The following is a description of a gene set: Cluster PAM6: genes changed exclusively in normal liver tissue adjacent to hepatocellular carcinoma (HCC) from mice deficient for TXNIP. species: Mus musculus The molecular pathogenesis and the genetic aberrations that lead to the progression of hepatocellular carcinoma (HCC) are largely unknown. Here, we demonstrate that the thioredoxin interacting protein (Txnip) gene is a candidate tumor suppressor gene in vivo. We previously showed that the recombinant inbred congenic strain HcB-19 has a spontaneous mutation of the Txnip gene, and we now show that the strain has dramatically increased incidence of HCC, and that the HCC cosegregates with the Txnip mutation. Approximately 40% of the Txnip-deficient mice developed hepatic tumors with an increased prevalence in male mice. Visible tumors develop as early as 8 months of age. Histological analysis confirmed the morphology of HCC in the Txnip-deficient mice. Molecular markers of HCC, alpha-fetoprotein and p53, were increased in tumors of Txnip-deficient mice. The upregulation of p53 preceded tumor development; however, bromodeoxyuridine (BrdU) labeling of normal hepatic tissue of Txnip-deficient mice did not reveal increased cell proliferation. Finally, microarray analyses of tumor, non-tumor adjacent, and normal tissue of Txnip-deficient mice highlighted the genetic differences leading to the predisposition and onset of HCC. Our findings suggest that Txnip deficiency is sufficient to initiate HCC and suggest novel mechanisms in hepatocarcinogenesis. Human Gene Set: SHETH_LIVER_CANCER_VS_TXNIP_LOSS_PAM6 from publication Sheth SS, Bodnar JS, Ghazalpour A, Thipphavong CK, Tsutsumi S, Tward AD, Demant P, Kodama T, Aburatani H, Lusis AJ (PMID 16607285), and this is the list of marker genes: PER2, RAB27B, CENPK, PRCP, CREB1, UHRF1, FAM110A, PDLIM5, RNF20, APLNR, CD93, TEF, LEPR, MATN4, HMG20A, RAB33A, PER3, PLA2G4F, ICOSLG, PITPNM1, TUBA3D, KCNK10, RTN4R, LARP6, TBC1D15, RRM2, ECT2, PTPN21, HDAC7, SIKE1, KRTAP6-1, USP12, USP2, WEE1, NFATC4, IL1R2, MKNK2, AGPAT5, SYT11, USP9X, NGEF, SPTLC2, NCAN, ELK4, TAF1D, BAMBI, SEPTIN8, LIPT2 (NCBI Gene Id 650826), SOCS3, MLF1, MMP10, MED19, TRIM24, DBP, DUSP7